The following is a description of a gene set: Genes up-regulated in primary LEC cells (lymphatic endothelum) upon overexpression of MIR31. from publication Pedrioli DM, Karpanen T, Dabouras V, Jurisic G, van de Hoek G, Shin JW, Marino D, Kälin RE, Leidel S, Cinelli P, Schulte-Merker S, Brändli AW, Detmar M (PMID 20479124) species: Homo sapiens The lymphatic vascular system maintains tissue fluid homeostasis, helps mediate afferent immune responses, and promotes cancer metastasis. To address the role microRNAs (miRNAs) play in the development and function of the lymphatic vascular system, we defined the in vitro miRNA expression profiles of primary human lymphatic endothelial cells (LECs) and blood vascular endothelial cells (BVECs) and identified four BVEC signature and two LEC signature miRNAs. Their vascular lineage-specific expression patterns were confirmed in vivo by quantitative real-time PCR and in situ hybridization. Functional characterization of the BVEC signature miRNA miR-31 identified a novel BVEC-specific posttranscriptional regulatory mechanism that inhibits the expression of lymphatic lineage-specific transcripts in vitro. We demonstrate that suppression of lymphatic differentiation is partially mediated via direct repression of PROX1, a transcription factor that functions as a master regulator of lymphatic lineage-specific differentiation. Finally, in vivo studies of Xenopus and zebrafish demonstrated that gain of miR-31 function impaired venous sprouting and lymphatic vascular development, thus highlighting the importance of miR-31 as a negative regulator of lymphatic development. Collectively, our findings identify miR-31 is a potent regulator of vascular lineage-specific differentiation and development in vertebrates. Human Gene Set: PEDRIOLI_MIR31_TARGETS_UP, and this is the list of marker genes: PRR15, INHBA, KRTAP9-2, NRG1, BMP8B, ANKRD54, CST13P, C20orf203, IDS, GPATCH4, NXPE2, MGARP, PDE4D, PRKCE, CLPSL2, RNF112, TAGLN, OR2A4, ANKRD2, SLC2A12, ASPH, KIAA1755, PLCE1, HS6ST3, OLFML2B, C17orf50, TYRP1, GP2, MAGEA11, IRX2, KRTAP17-1, SLC23A2, UCP2, SPRR4, LDB1, CD3E, TSSK1B, RASSF9, FZD5, BCAS4, GREB1L, LINC02874, CIBAR1P2, OR7D4, TAFA3, FOXS1, ARMC8, RASGRP2, ARK2N, PCTP, CD8B, KIF18A, HES7, GARIN5A, CDNF, LINC00482, REC8, PLSCR2, TNFRSF11B, C1orf53, RGS2, CXorf58, KCNJ15, CIDEC, LMNB1, PMEL, TYMSOS, ZNF740, SPON1, CEACAM16, G6PC2, CABYR, SMIM43, PHACTR3, CNTFR, FASN, ARHGAP4, FBLN5, CADM1, ANGPTL4, GATA3, AADACL4, HOXA2, PARP3, CCDC183, KRT7, ALX4 (ALX homeobox 4, NCBI Gene Id 64068), RAB20, ASTN2 (astrotactin 2), ADGRG6, ABI3BP, TTC9B, UTP25, LMO7, XPNPEP1, CFHR3, FAM221A, EAF2, TRPC2, GLYATL2, OR7C2, KRT80, PTCH2, HR, NDUFB11, PELI3, GABRR2, DOK3, RGS4, TMEM277P, OPALIN, MAPK8, DDIT4, CACNA1I, MAN2B2, ADRA1B, IGFBP3, CSMD1, TAF5L, PPIF, LIMS3, OLFML3, GK5, RAB26, PIP4K2B, SNX21, PFDN6, LINC00592, OR4K17, STBD1, CORO2A, L1CAM, MYLK2, GPC2, PMM2, NXF5, TTC28-AS1, PCDH10, LRATD1, BOLL, ZCWPW2, FUT3, SSX3 (NCBI Gene Id 10214), MCF2L2, RGS10, TTLL10, MYO7A, MGAT4A, SMAD5, PPME1, HS6ST1, JRK, AS3MT, CDKN2C (NCBI Gene Id 654235), ERN1, VSIG10L, ST3GAL4, SNRPC, FAM181A (family with sequence similarity 181 member A), P3H2 (prolyl 3-hydroxylase 2), RHOF, KRT17, ZNF366, CORO1A, ZBTB18, CISH, PIK3R3, PPAT, PKIA, RGMA, EVA1A, KLHL29, NPPC, ISM2, TAS2R38, UBE2V1, PDCD4, MMP1, LRRC8E, SLC35G1, EMC10, TTTY4, PSG11, NAALADL1, ATP2B4, STAT3, ZNF667, GJE1, ATOH1, STK11IP, ZNF555, MOB1B, SLC11A2, RAD52, IKZF4, DGKI (NCBI Gene Id 9162), ATAD2, ZNF699, RP2, STIP1, ENC1, CLSPN, ERBB2, NWD2, LDHAL6B, PHF7, NOTCH2NLA, OR7G3, ZFP69B, LRP2BP, TDG, TOMM22P3, OBSCN, HIPK3, SFTPA2, KRT81, CCL16, MUC5AC, ASB9, PCDHGC4, MPZL2, GLDC, ZNF484